Given this list of marker genes B3GNT7, GALNT7, B3GNT2, GALNT13, GCNT1, ST6GAL1, GCNT4, ST3GAL2, GALNT3, GALNT12, B3GNT4, GALNT14, CHST4, GXYLT1, ST6GALNAC2, GALNT4, GALNT9, GALNT1, POMGNT1, GALNT5, GXYLT2, ST3GAL4, GALNT6, B4GALT5, B3GNT5, ST6GALNAC4, ST3GAL1, GALNT15, B3GNT6, A4GNT, XXYLT1, GALNT2, B3GNT3, ST3GAL3, B3GNT8, GALNT8, GCNT3, GALNT11, GALNT10, here is a description of the gene set: studied in species Homo sapiens Human Gene Set: GOBP_O_GLYCAN_PROCESSING The stepwise addition of carbohydrate or carbohydrate derivative residues to the initially added O-linked residue (usually GalNAc) to form a core O-glycan structure.